The following is a description of a gene set: species: Homo sapiens part of: Drug ADME Reactome Pathway: Abacavir ADME Abacavir is a nucleoside analogue reverse transcriptase inhibitor with antiretroviral activity, widely used in combination with other drugs to treat HIV-1 infection. Its uptake across the plasma membrane is mediated by organic cation transporters SLC22A1, 2, and 3; the transport proteins ABCB1 and ABCG2 mediate its efflux. Abacavir itself is a prodrug. Activation requires phosphorylation by a cytosolic adenosine phosphotransferase and deamination by ADAL deaminase to yield carbovir monophosphate. Cytosolic nucleotide kinases convert carbovir monophosphate to carbovir triphosphate, the active HIV reverse transcriptase inhibitor. Abacavir can be glucuronidated or oxidized to a 5'-carboxylate; these are the major forms in which it is excreted from the body., and this is the list of marker genes: SLC22A3, SLC22A1, ABCB1, NT5C2, PCK1, SLC22A2, ABCG2, ADH1A, MAPDA